Given this list of marker genes MIR19A, MIR27B, ELN, IHH, MIR18A, FBLN5, TIE1, MYH11, MIR98, PPARG, MIR19B1, NTN4, COL6A1, LTBP4, HAPLN2, THSD4, EFEMP2 (NCBI Gene Id 30008), SMPD3, MIR9-1, TGFB1, RGCC, HAS2, TGFBR3, SOX9, SMAD3, MIR483, EMILIN1, PLOD3, HAS3, ANTXR1, PXDN, ATP7A, RAMP2, MIR29B1, LOX, COL3A1, PRICKLE1, GAS6, COL1A2, TGFBR1, SMAD4, NOTCH1, HAS1, FKBP10, TNXB, QSOX1, MIR145, MFAP4, AGT, GPM6B, here is a description of the gene set: species: Homo sapiens The aggregation, arrangement and bonding together of the extracellular matrix. Human Gene Set: GOBP_EXTRACELLULAR_MATRIX_ASSEMBLY